Given this list of marker genes Brcc3dc, Eif3f, Psmd14, Stambpl1, Eif3h, Cops5, Brcc3, Mysm1, Stambp, here is a description of the gene set: studied in species Mus musculus Mouse Gene Set: GOMF_METAL_DEPENDENT_DEUBIQUITINASE_ACTIVITY An metal-dependent isopeptidase activity that cleaves ubiquitin from a target protein to which it is conjugated.